The following is a description of a gene set: species: Homo sapiens Any process that activates or increases the frequency, rate or extent of the directed movement of a motile cell or organism in response to a specific chemical concentration gradient. Human Gene Set: GOBP_POSITIVE_REGULATION_OF_CHEMOTAXIS, and this is the list of marker genes: CDH13, BMPR2, S1PR1, APP, S100A14, LGALS9, TMSB4X, CCL26, SEMA5A, IL6R, DEFB124, SERPINE1, NEDD9, PGF, PRKD2, MET, MAPK3, SWAP70, CXCL17, RAC2, C1QBP, RAC1, CCL3, AKIRIN1, MEGF8, CCR2, C3AR1, F3, NTF3, DNM1L, WNK1, ARTN, EDN2, PPM1F, IL12A, IL16, TMEM102, LGMN, ADAM10, TIRAP, CD74 (NCBI Gene Id 972), FGF18, F7, PDGFRA, CXCL12, PTK2, CCL1, F2RL1, EDN3, THBS1, ITGA2, P2RX4, CCL5, STX3, TRPV4, TNFSF14, NCKAP1L, DSCAM, KDR, VEGFC, RARRES2, AGER, SLAMF1, CASR, CREB3, SCG2, VEGFA, P2RY12, CCL2, TPBG, XCL1, NRP1, STX4, PRKD1, CMKLR1, MAPK1, RIPOR2, CXCL13, FGFR1, PERP, SMOC2, S100A7, IL23A, EDN1, THBS4, NTRK3, CXCR3, FPR2, OXSR1, CTTN, CCR6, CAMK1D, FGF16, ADAM17, PDGFRB, PTK2B, SLIT2, FGF2, STK39, ANO6, GAS6, MOSPD2, DAPK2, MCU, DEFB131A, TGFB1, VEGFB, CX3CR1, CXCL10, MDK, PLA2G7, AIF1, PTPRJ, PDGFB, CSF1, LPAR1, SUCNR1, PDGFD, FGF10, LBP, IL6, CCR7, VEGFD, TNFSF18, GPSM3, HMGB1 (NCBI Gene Id 3146), CCL21 (C-C motif chemokine ligand 21), CXCL8, CCR1, PTN, SPI1, C5AR1, HSPB1, CCL4, CCL7, CALR, MSTN, SMAD3, ZNF580, TREM2, AZU1, WNT5A, CSF1R, CCL19, IL34